The following is a description of a gene set: Human Gene Set: MIR6753_3P Genes predicted to be targets of miRBase v22 microRNA hsa-miR-6753-3p in miRDB v6.0 with MirTarget v4 prediction scores > 80 (high confidence targets). from publication Chen Y, Wang X (PMID 31504780) species: Homo sapiens, and this is the list of marker genes: EVC, SPTBN1 (NCBI Gene Id 91654), PDPK1, KSR2, SERPING1, PAPSS1, CERK, CTHRC1 (NCBI Gene Id 115908), GNAL, BICD2, PPP4R3B, TMEM91, NAGPA, NDRG1, SLC22A23, NAA15, P2RY1, CHD2, THSD7A, NPHP1 (nephrocystin 1), FBLIM1, SLC19A4P, XPO5, MBNL2, SUPT7L, NFAT5, AUTS2, TENT2 (NCBI Gene Id 167153), MTF2, SELENOT, ADAMTS19, RAB11FIP4, CREB3L3, PRG4, TBX5, MON2, PRLR (NCBI Gene Id 5618), DNAJC6, NFIA, CTNND1 (NCBI Gene Id 82168), SRC, SGSM2, SLC1A1, RAD21, ASIC2, SOX11, RAB30, UBE2Z, PIP5KL1 (phosphatidylinositol-4-phosphate 5-kinase like 1), RC3H1, SRP9, CLIP3, PPP1R9B, PAK5